Given this list of marker genes Sema3a, Tex11, Stc2, Knstrn, Pole4, Wapl, Smc1b, Dnajc27, Usp45, Ulk1, Eif5, Neto1, Nemp1 (NCBI Gene Id 72243), Ptprn2, Sftpa1, Ei24 (NCBI Gene Id 13663), Syncrip, Hdgfl3, Lhx9, Shisa7, Tnc, Kctd2, Amph, Foxj3 (forkhead box J3), Spata3, Acsm2, Dact1, Znhit6, Slco1a6, Kat8, Pde4d, Clxn, Ptp4a2, Mtf2, Eda2r, Ajap1, Vps13d, Eaf1, Ddo, Cyp7a1, Lats2, Pom121l2, Brd10, Vav3, Aspn, Kctd14, Cntln, Elovl5, Sh3rf1, Tmtc3, Kng1, Prdm8, Phip, Dek, Ocrl, Cadps2, Bcor, Larp4b, Ap3m1, Hnrnpab, Erfe (NCBI Gene Id 227358), Rpsa, Serpinb9g, Lgi4, Ppp4r3a, Wdr59, Gpatch2l, here is a description of the gene set: Genes predicted to be targets of miRBase v22 microRNA mmu_miR_425_5p in miRDB v6.0 with MirTarget v4 prediction scores > 80 (high confidence targets). Mouse Gene Set: MIR_425_5P studied in species Mus musculus from publication Chen Y, Wang X (PMID 31504780)